Given this list of marker genes PLIN1, RXRA, NR1H3, NR1H2 (nuclear receptor subfamily 1 group H member 2), RXRB, here is a description of the gene set: part of: NR1H2 and NR1H3-mediated signaling Adipose tissue triglycerides (TGs) represent the major energy store of the body. During adipocyte lipolysis triglycerides (TGs) are hydrolyzed into free fatty acids (FFAs) and glycerol by the action of adipose triglyceride lipase (ATGL, encoded by PNPLA2), then hormone-sensitive lipase (HSL), which is activated by glucagon and adrenaline (epinephrine) and inhibited by insulin. Both isoforms of liver X receptor, LXRα (NR1H3) and LXRβ (NR1H2), are expressed in mature mouse and human adipocytes (Juvet LK et al. 2003). Expression of NR1H3 is up-regulated during adipocyte differentiation (Juvet LK et al. 2003; Darimont C et al. 2006). Ligand activation of LXRs (NR1H2 or NR1H3) can induce adipocyte lipolysis and FFA oxidation (Stenson BM et al. 2011; Ross SE et al. 2002). For instance, in mouse 3T3L1 adipocytes and human primary adipocytes, LXR activation led to an increase in basal, but not hormone-stimulated, lipolysis as measured by glycerol release (Ross SE et al. 2002; Stenson BM et al. 2011). Another study showed that administration of synthetic ligands of NR1H2/ NR1H3, T0901317 or GW3965, to mice resulted in smaller adipocytes and increased serum free fatty acid and glycerol concentrations, suggesting increased adipocyte lipolysis (Commerford SR et al. 2007). Further, microarray analysis of human adipocytes following NR1H3 or NR1H2 activation revealed altered gene expression of several lipolysis-regulating proteins such as perilipin1 (PLIN1), which was also confirmed by quantitative real-time PCR (Stenson BM et al. 2011). Selective knockdown of either NR1H2 or NR1H3 showed that NR1H3 (LXRα) was the major isoform mediating the lipolysis-related effects of LXR agonists (Stenson BM et al. 2011). In addition, the absence of NR1H3 (LXRα) in mouse adipose tissue resulted in elevated adiposity through a decrease of both lipolytic and oxidative capacities in white adipose tissue (Dib L et al. 2014). species: Homo sapiens Reactome Pathway: NR1H2 & NR1H3 regulate gene expression linked to triglyceride lipolysis in adipose